The following is a description of a gene set: The process in which ions are transported across the plasma membrane of a cardiac muscle cell such that the membrane potential changes in the repolarizing direction, toward the steady state potential. For example, the repolarization during an action potential is from a positive membrane potential towards a negative resting potential. Human Gene Set: GOBP_CARDIAC_MUSCLE_CELL_MEMBRANE_REPOLARIZATION studied in species Homo sapiens, and this is the list of marker genes: KCNH2 (NCBI Gene Id 4027), KCNH6, KCNQ1 (NCBI Gene Id 3784), KCNN2, SNTA1 (syntrophin alpha 1), CAV3, ATP1A1, GJA5, WDR1, KCNE2, KCNJ5, SCN4B, KCNE1, KCNIP2, SCN2B, KCNE3, KCNJ2, YWHAE, FLNA, SCN5A, CACNA1D, ZMPSTE24, MIR328, RNF207, CACNA2D1, KCND3, KCNE5 (NCBI Gene Id 23630), CASQ2, MIR1-1, DLG1, NOS1AP, KCNJ3, NPPA, SCN1B, ANK2, ATP1B1, KCNA5, AKAP9, KCNJ8, KCNE4, MIR133A1, NOS1